The following is a description of a gene set: Genes predicted to be targets of miRBase v22 microRNA hsa-miR-4528 in miRDB v6.0 with MirTarget v4 prediction scores > 80 (high confidence targets). Human Gene Set: MIR4528 from publication Chen Y, Wang X (PMID 31504780) species: Homo sapiens, and this is the list of marker genes: FLRT2, PAX3, HACE1, COPS8, PAX6, BLTP1, CHEK1, GPCPD1, AGMO (alkylglycerol monooxygenase, NCBI Gene Id 442510), KRT10-AS1, GTF3C4, ZNF354B, SRGN, HHEX, ZMYM2, KLHL2, TMPRSS12, PRDM13 (NCBI Gene Id 59336), ANP32E, FUT9, TSNAX, IGF2BP3, ZBTB38, PPP2R5A, PHC3, ABCA10, GNPNAT1, TMED7-TICAM2, ANKIB1, MAP3K2, LYPLAL1, TEX12, PMAIP1, PBRM1, CRIM1, ABHD3, LRP5L, KCNK1, LBR, RFX7, TRIM6, CUL3, ANKRD6, FKBP14, RAP1A, CCDC179, RBMS1, MAP3K7, SCAPER, CR1, CCSER1, CHST9, IRAK3, WDR35, LPP, AKR1D1, IRX2, ZFAND4, ZNF28, NAMPT, CDCA2, STARD4, PPP4R4, UBN2, ERF, DCDC2, CHUK, TNKS2, WDR72, CCL2, ANGEL2, IQCA1, CUL2, SLC37A3, IRAK1BP1, ZNF37A, TNRC6A, GCNT1, DDX59, RREB1, BIVM, CLDN8, SPHKAP, SLC30A4, SLC39A12, ZFP2, VPS11, USP14, ZNF571, SGCB, SLC38A2, TRDN, MEIOC, TENM3, UBA3, RBM17, PUM1, EYS, CERT1, PAPSS2, LIN7C, GK, TMEM184C, ZNF215, IQCH, UBE2B, ZNF608, GIMAP2, VPS26A, GMPR, RBBP6, EML1, GOSR1, FOXR2, TVP23C, MDM2, PCDH15, SEC24B, GNRHR, CAV2, NECTIN3, CREB1, ZNF506, LRRC3B, HNRNPH3 (heterogeneous nuclear ribonucleoprotein H3), EIF5, TGFB2, GYPA, HOXD8, SLC52A1, TAS2R14, ACSL6, PRDM16 (PR/SET domain 16), MLF1, KALRN, PTPN4, ZFYVE28, RTKN2, TMEM237, ABTB3, ZNF546, WNT11, AKAP6, EGR3, IL36G, LGSN, RAP2C, SNAPC3, FBXO30, ALG9, EPDR1, PDE12, PHF3, UBE2H, ZNF16, GK2, ZNF26, BCLAF3, ICE1, AAK1, ANKRD13C, CFL2, ASCC3, PDP2, GLYATL3, TMEM123, CMYA5, PGR, CNBP, ME1 (NCBI Gene Id 4199), TACC1, ODR4, GJA3, TSC22D2 (TSC22 domain family member 2), GATA6, ZNF518B, HOXA9, PRH2, C5orf24, NF1, MAT2A, FH, IFT27, TMEM50B, SLITRK4, PEX3, HBS1L, CAMK1D, OPRM1, MAP2, MSR1, ZHX1, MAP9, NRBF2, LIPG, PALM2AKAP2, PPIL3, TMEM168, GFM2, TWSG1, DBR1, MGST1, CDH5, GPATCH2L, HDAC9, MITD1, GTPBP10, EIF5A2, SCAI, RPS6KA6, KCTD1, IBSP, KLHDC1, NR2F1, YTHDF3, AMZ1, DENND4C, ORMDL1 (NCBI Gene Id 94101)